Given this list of marker genes MAPK3, BRAF, PPP2R1A, PPP2CB, PTPN11, MAPK1, UBB, CBL, PPP2CA, UBA52, RPS27A, GRB2, MKNK1, SRC, UBC, SPRY2, here is a description of the gene set: species: Homo sapiens Reactome Pathway: Spry regulation of FGF signaling part of: Negative regulation of FGFR1 signaling; Negative regulation of FGFR2 signaling; Negative regulation of FGFR3 signaling; Negative regulation of FGFR4 signaling Sprouty was initially characterized as a negative regulator of FGFR signaling in Drosophila. Human cells contain four genes encoding Sprouty proteins, of which Spry2 is the best studied and most widely expressed. Spry proteins modulate the duration and extent of signaling through the MAPK cascade after FGF stimulation, although the mechanism appears to depend on the particular biological context. Some studies have suggested that Sprouty binds to GRB2 and interferes with the recruitment of GRB2-SOS1 to the receptor, while others have shown that Sprouty interferes with the MAPK cascade at the level of RAF activation. In addition to modulating the MAPK pathway in response to FGF stimulation, Sprouty itself appears to be subject to complex post-translational modification that regulates its activity and stability.